The following is a description of a gene set: part of: Apoptosis This event has been computationally inferred from an event that has been demonstrated in another species.<p>The inference is based on the homology mapping from PANTHER. Briefly, reactions for which all involved PhysicalEntities (in input, output and catalyst) have a mapped orthologue/paralogue (for complexes at least 75% of components must have a mapping) are inferred to the other species. Reactome Pathway: Caspase activation via extrinsic apoptotic signalling pathway species: Mus musculus electronically inferred by orthology from the curated human pathway, and this is the list of marker genes: Fasl, Fas, Casp8, Tradd, Casp9, Tlr4, Casp3, Cd14, Ticam2, Fadd, Ly96